Given this list of marker genes ADORA2A, GTF2B, ARHGEF33, MYEOV, RUNDC3B, PAG1, TMEM263, HECTD2, ANKRD17, USF3, ZFP1, XRN1, VPS13D, YWHAB, CHURC1, ASTN1, EIF4A2, SIX1, URM1, KIAA1958, MPST, NEXMIF, WNT5A, YIPF6, ARHGAP24, CMPK2, CDC7, ORC4, C21orf91, FOXD2, IGSF3, USP9X, THG1L, CDC42EP4, PEX2, CXADR, KCNK1, AGBL5, ZNF606 (NCBI Gene Id 80095), DCUN1D5, TPGS2, SYNPO2, TUT7, LZIC, PACSIN2, THSD7B, VASP, GPR161, LCORL, CNPY1, CTBP2, SLC16A1, VTI1A, TBPL1, PSIP1, CYP20A1, FIBIN, RGS8, CD44, KDM2A, RPS6KA5, PTPRT (NCBI Gene Id 11122), SLC25A25, CREBRF, SLFN14, STRAP, IGF2BP2, BRINP1 (NCBI Gene Id 1620), CREB1, TET2, GUCY1A1, PPP1R3C, SYPL2, NBEA, EBF3, KAT2B, CLOCK, PIGA (NCBI Gene Id 5277), FASLG, ANKRD33B, MBNL1, HHAT, CARNMT1, PTPRB, CCDC50, NUP50, METTL14, SMC6, NXPH1, SLA, AAK1, ZNF800, KNSTRN (NCBI Gene Id 90417), PABIR3, ACTR3, ASF1A, TAS2R13, HOXA9, CCR7, MTMR1 (NCBI Gene Id 8776), MED8, CLMN, CPD, SIGLEC6, PSTPIP2, MAP4K5, TMOD2, DENND4A (NCBI Gene Id 10260), NRG3, HMGXB4, DNAJA2, MIB1, UBE4A, NCK1, ATP8B2, SYCP2, TNFSF10, FRMD3, PHEX, ANKRD7, CXCL12, HOOK3, RBMS3, ADAMTS5 (ADAM metallopeptidase with thrombospondin type 1 motif 5), SKIL, FSHR, PCDH17, PLA2G12B, BBS5 (NCBI Gene Id 428), INO80D, TMPRSS13, ENAH, PHC3, GPR180, PRTG, EDN2, UBE2J1, KCNMA1, RBM15, CCNY (cyclin Y), ZNF835, CREBBP, OSBPL11, SENP6, GTF2H3, TMEM164, C9orf85, SMYD1, USP34, PIKFYVE (phosphoinositide kinase, FYVE-type zinc finger containing), ABCB10, CACUL1, SEC63, KDM6B, PEX1, FAM168A, RAB33B, GDE1, PRAME, BCOR (BCL6 corepressor), FBN2, PSMD1, DRICH1, C14orf132, F13B, PREB, KIAA0930, CHD2, ITM2B, RELB, MCOLN3, AEBP2, OPRM1, LRRFIP1, AMACR, CDC14A, C3orf70, VWC2, ENPP2, IGFBP5, HTR1B, RTN4, BTBD7, OMA1, TMEM221, HOOK1, RAP1A, DONSON, VIRMA, FADS1, SUCO, POLR1D, KHDRBS2, DPH6, ALCAM, ESM1, RBM41, CAB39, ABTB3, PCNT, PKP4, MAGI1, ZNF326, JADE1, LRP2, DDX54, TNKS, HYDIN, MAST4, BLTP3A, NUAK1, CADM2, ZKSCAN1, RABL2B, JAG1, SREK1, KSR2, LIN54, IL17RD, XIRP2, SERPINB12, EVI2A, ARL14, SMARCAD1, TAF1A, ZNF280D, C5AR1, TRPM7, NOL7, PIGB, SYS1, MPV17L, NSRP1, NECTIN3, MLANA, ELOVL4, AIFM2, LDLRAP1, DCUN1D3, KLHL32, SYNPO, PCNX1, MUC19, SKAP1, C1GALT1, NFIA, SRPX2, NCOA1, SDHD, CCNB2, CDK8 (cyclin dependent kinase 8), ATP2A2, UBE2Z, TLK2, ADAMTS1, MANEA, ZMAT1, NF1, PSMC2, TENM1, YTHDF2, TXNDC9, ZNF684, CHST3, ID1, PHTF2, ADGRL3, GRIA1, EIF4A1, RAB21 (NCBI Gene Id 23011), MRPL35, GNA11, NPTN, PDLIM3, HMG20A, GABRA5, CCPG1, SPRY3, CCT4, MINDY2, SAXO1, SESN3, ZNF746, RSPRY1, ARHGAP11A, GSPT1, CHIC1, TBK1, MLEC, ZNF507, SCN9A, MED13, PLEKHM3, ST8SIA4, IP6K1, ADCY7, here is a description of the gene set: from publication Chen Y, Wang X (PMID 31504780) studied in species Homo sapiens Genes predicted to be targets of miRBase v22 microRNA hsa-miR-670-3p in miRDB v6.0 with MirTarget v4 prediction scores > 80 (high confidence targets). Human Gene Set: MIR670_3P